Given this list of marker genes ANXA10, HMMR, UBAP2L, SLC25A51, FNBP1 (NCBI Gene Id 23048), SAA2 (serum amyloid A2), TAL2, CATSPER1, SKA2, RDH10, SWAP70, CEL, MYO1B, SFXN1, AOAH (NCBI Gene Id 313), OARD1, ACKR4, KALRN, CBX4, HLCS, DYNLT1, MYH1, NEIL3, RLN1, LAD1, SLC45A3, MATK, CASP8 (caspase 8), PAX7, SELENOH, NGLY1, NDUFS8, PSME1, MRPL16, LRFN1, SDHD, NIT1, SCN3A, ANKRD22, HAUS7, ITM2A, CDKN2C, RAD54L, BDH1, MAPRE2, RBBP8, BRCA2, ZMIZ2, TPM2, MTA1, PCDHB4, KIF20A, ASF1A, MRPL14, FIGNL1, CA6, CAVIN1, PSD, COLQ, SAMSN1, EMC10, ECHDC1, MGST2, UAP1L1, SND1, SLC41A3, CACNA1A, INPP4A, DUOXA1, AGBL5, SLC30A3, KHK, INTS6L, NFKBIE, SEPTIN7, CYS1 (NCBI Gene Id 192668), ZNF426, ADCY8, ADGRE5, ADH1C, CASP2, TRIM31, ZNF395, GPR19, STK10, DUSP9, HIVEP1, ARL6IP4, KIF17, HEPH, PCCA, KCNK1, MRPL4, KCNE1, NUB1, TRAF5, CD99, ERMP1, PSPH, CEP19, PPM1G, SLC22A2, PARK7, MGP, ATL3, ADAM10, PSMG1, TNS1, ZKSCAN3, ADSS1, LGALS7, C12orf57, PTPRCAP, BCKDHB, ADCYAP1, DPP8, RASA1, ENSG00000285566, TRIM21, SCG3, JARID2, C6orf62, MINPP1, REEP5, ANAPC13, HPCAL1, DGUOK, IRF2, NAB1, APIP, AP3S1, CHURC1, COPS6, PECAM1, GSTM2 (NCBI Gene Id 82152), TCTE1, COPG2, SIDT1, NFE2L2, FBXO4, PIP4K2A, JUND, OXSM, FASLG, UBALD1, MYL6B, VPS26C, ENO3, NDUFA8, GPR143, UFC1, GSTZ1, MMP3, OAT, TBL1XR1, EDN2, BRCC3, CD3G, LXN, TMEM37, TNFSF11, SHOX2, RTN4IP1, S100A11, HOXB3, NFE2L3, TGFA, BTBD2, CEP89, SMPDL3A, SLC25A42, APOBR, COQ8B, IL36A, DCX, EPSTI1, CRKL, EIF3B, UBR7, TMEM71, RIPOR2, ACTR3, TPRG1L, TMEM38B, NPEPPS, KIF11, MCM10, CDK1, TEX101, CNTNAP2, MNS1, CHTF8, SDHAF4, TSEN15, RAPGEF6, IFITM3, ABCG8, TRPC4, CDCA3, here is a description of the gene set: Genes up-regulated in lymphoid-primed multipotent progenitors versus granulo-monocyte progenitors. Regulation of lineage potential and transcriptional priming by Ikaros. New insight is provided into a bivalent regulation of lineage priming in the HSC and its lympho-myeloid restricted progeny the LMPP by the lymphoid lineage-determining factor Ikaros Whereas Ikaros is responsible for the activation of a cascade of lymphoid expression programs and for the establishment of lymphoid potential from the HSC to the LMPP it is also responsible for the repression of stem cell and erythroid genetic programs that are incompatible with further lineage restrictions emanating from the LMPP from publication Ng SY, Yoshida T, Zhang J, Georgopoulos K (PMID 19345118) studied in species Homo sapiens Human Gene Set: GSE15330_LYMPHOID_MULTIPOTENT_VS_GRANULOCYTE_MONOCYTE_PROGENITOR_UP